Given this list of marker genes Cdk20, Smo, Cluap1, Gli2, Gli1, here is a description of the gene set: species: Mus musculus The process whose specific outcome is the progression of the ventral midline over time, from its formation to the mature structure. In protostomes (such as insects, snails and worms) as well as deuterostomes (vertebrates), the midline is an embryonic region that functions in patterning of the adjacent nervous tissue. The ventral midline in insects is a cell population extending along the ventral surface of the embryo and is the region from which cells detach to form the ventrally located nerve cords. In vertebrates, the midline is originally located dorsally. During development, it folds inwards and becomes the ventral part of the dorsally located neural tube and is then called the ventral midline, or floor plate. Mouse Gene Set: GOBP_VENTRAL_MIDLINE_DEVELOPMENT